Given this list of marker genes DDX21, ADAMTS4, IGFBP7, CSF3, LITAF, PTPRE, C11orf96, ICAM1, SOD2, PNP, ABL2, EMP1, BIRC3 (baculoviral IAP repeat containing 3), CXCL8, UGCG, TUBB6, SERPINB1, VCAM1 (NCBI Gene Id 7412), NNMT, NDRG1, CXCL2, CLU, PMP22, RND1, GJA1, TMEM70, ISG20, CCL2, TIMP1, HIF1A, ADAMTS9, PLVAP, THBS1, ETS2, ACKR1, SELE, NCOA7, CDKN1A, C2CD4B, POSTN, IER3, NFKBIA, ARID5A, IL6, NAMPT, AKAP12, TNFAIP3, MYC, LMNA, MT1A, here is a description of the gene set: In this study, an extensive analysis was conducted to define meta-programs (MPs) capturing intra-tumor heterogeneity across a spectrum of tumor types. The approach utilized non-negative matrix factorization (NMF) to analyze each cell type separately within individual tumor samples. This involved the analysis of malignant cells, macrophages, fibroblasts, endothelial cells, epithelial cells, T-cells, and B-cells. NMF was executed with varying parameter values (K=4, 5, 6, 7, 8, 9), thereby generating 39 programs for each cell type per sample. Each NMF program was summarized by the top genes based on NMF coefficients.\nRobust MPs were then delineated for each cell type using a set of stringent criteria, including recurrence within the same tumor, similarity to programs in other tumors, and non-redundancy within a tumor. Subsequently, these robust NMF programs were clustered (per cell type) based on Jaccard similarity, leading to the identification of MPs associated with each cell type.\nTo enhance the quality of the MPs, a refinement steps were undertaken, involving the removal of MPs suspected of reflecting low-quality data (with an overrepresentation of ribosomal proteins or mitochondrial-encoded genes), single-study inclusion, or similarity to miss-annotated cell types. from publication Gavish A, Tyler M, Greenwald AC, Hoefflin R, Simkin D, Tschernichovsky R, Galili Darnell N, Somech E, Barbolin C, Antman T, Kovarsky D, Barrett T, Gonzalez Castro LN, Halder D, Chanoch-Myers R, Laffy J, Mints M, Wider A, Tal R, Spitzer A, Hara T, Raitses-Gurevich M, Stossel C, Golan T, Tirosh A, Suvà ML, Puram SV, Tirosh I (PMID 37258682) studied in species Homo sapiens Human Gene Set: GAVISH_3CA_METAPROGRAM_ENDOTHELIAL_NF_KB Genes upregulated in subsets of cells of a given type within various tumors